Given this list of marker genes CRLS1, here is a description of the gene set: part of: Glycerophospholipid biosynthesis species: Homo sapiens Reactome Pathway: Synthesis of CL Cardiolipin(CL) is synthesized in the inner mitochondrial membrane, when phosphatidylglycerol (PG) and cytidine diphosphate-diacylglycerol (CDP-DAG) are converted into CL. In addition to be synthesized in mitochondria, CDP-DAG may also be imported from ER to serve as the cardiolipin precursor pool. PGP (phosphatidylglycerol phosphate) catalyzes rate limiting step of cardiolipin biosynthesis.